Given this list of marker genes Dtx4, Dtx1, Rps27a, Dtx2, Ep300, Ubb, Snw1, here is a description of the gene set: This event has been computationally inferred from an event that has been demonstrated in another species.<p>The inference is based on the homology mapping from PANTHER. Briefly, reactions for which all involved PhysicalEntities (in input, output and catalyst) have a mapped orthologue/paralogue (for complexes at least 75% of components must have a mapping) are inferred to the other species. studied in species Mus musculus Reactome Pathway: Signaling by NOTCH1 part of: Signaling by NOTCH electronically inferred by orthology from the curated human pathway